Given this list of marker genes H3C14, LDLRAP1, ACAD9, GCDH, YKT6, PPM1M, PTRH1, GSTO1, SERINC3 (NCBI Gene Id 10955), TBC1D24, HGSNAT, ADRB2, PMPCA, SCNN1A, SP6, MCEE, ALKBH4 (alkB homolog 4, lysine demethylase), AK1, LARP1B (La ribonucleoprotein 1B), YPEL5, UNC119B, LHX2, TRIM11, ZNF426, MYD88, TECPR1, CD68, GTF2B, CMPK2, WSB1, ZNF764, DNAJA1, TNFRSF18 (NCBI Gene Id 8784), SKIC8, ATP6V0D1, NANOS1, SLC10A6, PDRG1, GPR146, USP17L24, SLC25A33, NT5DC3, GCH1, PLS3, SLC39A7, PDLIM5, SHMT2, PRKRIP1, EFNB1, MSRB1, TK2, IFNGR2, FTSJ3, BECN1, ENDOD1, OLA1, ROM1, SIVA1, NAT8, TSPAN7, ACAA1, GAL3ST1, GTSE1, TUBB4B, HOXA5, ADAMTS15, EOGT (NCBI Gene Id 79580), CORO1A, PPP5C, ACSL1, TUT7, AREG, ZPR1 (NCBI Gene Id 95155), RIC8A, IMPA1, CRLF1, RAP2A, PURG, GPLD1, GORASP1, KLF17, PNP, CAMP, ASAH2, SLC35D1, SLC45A3, PPP1R37, WDR46, IFITM10, SF3A1, DCXR, TRIM17 (NCBI Gene Id 51127), CABYR, TBC1D1, MLF2, SH3BGRL3, UBA7, QSOX1, KCTD11, TMEM140, CPOX, CELF4, OMP, ICAM5, NMNAT1, RRP9 (NCBI Gene Id 9136), COL4A4, TUFT1, EEIG1, ENTPD7, ATG3, NAPA, BCAP31, NATD1, BMP1, PSMF1, RNF225 (ring finger protein 225), NACC1, PSRC1, RABGEF1, NR4A1, SHISA5, H2BC13, CES2, HYAL1, LIG3, AGTPBP1, CUL4A, P2RY6, CCS, SESN2, UBE2V2, NUDT22, SEPTIN3 (septin 3), CHCHD10, POLR3D, UBN1, SCN1B, BAG1, POLR2A, RUSC1 (RUN and SH3 domain containing 1), RNPC3, MOAP1, ATG9B, DRG2, MARVELD1, NOP9, KCNK2, THBS1, OGFRL1, CDR2, STK17B, HYAL2, MR1, C8orf76, BRIX1, FOLR1, PTGER1, ZNF281, GFOD2, CBARP, CAMK2B, SELENOS, EED, MPP4, NPTX1 (NCBI Gene Id 4884), CSTB, CEP104, FAM32A, INHBB, TPRA1, IFI30, MAP2K3, ABTB1, HERC1, ZNF484, CD14, POLRMT, AHNAK, CCNL2 (NCBI Gene Id 9613), SH2D3C, PPIF, CIRBP, TTC16, LRWD1, OASL, RALGPS1, LTBP2, POM121, DEPDC7 (DEP domain containing 7), FAM8A1, UPF3B, ISYNA1, HAUS2, TGM2, TMC6, PLEC, OVOL1, FAM43A, NDRG4, SLC19A2, IRGM, HMGA1, KLHL10, CLDND1, SCARB1, GTF2F2, PRSS8, CTSV, TOR2A, C21orf91, ATOSB, TAPBP, LPGAT1, TRIM21, GCNT2, TOR3A (torsin family 3 member A), GPAT4, PTGER4, METTL6, C6orf132, NLRX1, DPP7, CD207, S100A3, RHBG, FZD7, USP20, RAB43 (NCBI Gene Id 339122, RAB43, member RAS oncogene family), TNFRSF21, SPON2, KCTD10, HPN, SPC25, DSTN, RGS16, EGR2, ZNRF2, PGRMC1, HERPUD2, PSAPL1, CNBD2, ECM1, DGAT2, DMPK, GALNT3, MACROD2, PEX6, PGF, SH3GLB2, TRABD, MTARC2 (NCBI Gene Id 96692), DRC3, ABHD4, ST14, VWA7, CROT, PTHLH, SDC1, CKAP2, FAM216A, CDK18, SBK1, RDM1, DPH7, C1S, ATP6V1E1, DOLK, TMEM150A, PDLIM7, FHL2, MIDN, FBXO33, TEX9, PDGFB, FRMD8, BCAR1, SLC12A7, EIF1AY, TMEM158, SIMC1, EPM2AIP1, CALHM2, CHP1 (NCBI Gene Id 11261), INPP5D, ADAM1A, SERPINE2, GTF2IRD2B, TUBA4A, CRKL, HSD17B4, LMBR1L, PDE1B, MID2, DEGS1, SPRYD4, SLC35F6, DEXI, HS6ST1, CCDC166, TTC27, WSB2, IRAK1BP1, EPHA2, COL17A1, TMEM132A, RHPN2, SLC25A44, MGAT2, AQP1, VAX2 (ventral anterior homeobox 2), DPCD, PIWIL2, C1QTNF1, NAT9, RPUSD1, NOPCHAP1, TMBIM1, GIPC2, ZNF622, INCENP, S100A1, PYGO2, ADGRL1, DESI1, SPR, CDR2L, PAQR4 (NCBI Gene Id 124222), GNA15, ALOXE3, HES6, WNT7B, INCA1, RGL1, COPS9, GRINA, IVD, EXOC4, DDIT4L, SLC18A1, DCAF1, RAP1GAP, MXD4, PSMB4, TTC39B, SORD, LMO4, TTC13 (NCBI Gene Id 79573), TOP3A, ENTREP3, AAR2, TSPAN33, EIF4EBP1, SMARCAD1 (SWI/SNF-related, matrix-associated actin-dependent regulator of chromatin, subfamily a, containing DEAD/H box 1), CCDC137, TEAD3, ARL16, SLC37A2, OAS2, MCFD2, ANKRD10, GUSB, UBE2I, SF3B5, CDIPT, GBP6, ARMC7, ATP13A2, CCN4, DFFB, IFI44, OASL2P, ZFAND2A, LRRC14, DNAJC9, MDM2, VEGFA, BAIAP2, RETSAT, MSANTD5, LGALS3BP, GFER, RBM4, CLDN23, LASP1, MYO5A, DENR, NFATC2, EXOSC9, PSMB9, LRFN1 (leucine rich repeat and fibronectin type III domain containing 1), SLC66A2, CYCS (NCBI Gene Id 54205), MTHFR (NCBI Gene Id 4524), ALDH2, AMPD2, PATZ1, PLIN2, APOH, AAMDC, ALDH1L1, SEC61A1, SPA17, AP4S1, CREM (cAMP responsive element modulator), MAN2B1, CEP295NL, BTG3, HMG20B, ADAMTS4 (NCBI Gene Id 9507), DBR1, ALAD, RASA4B, TAMALIN, MX1, UBE2T, PSTPIP1, TM2D2, CLEC4G, YIPF2, ITGA6, SNCG, NINJ2, ACOX2, NT5DC2, MITF, TMEM19, NDUFA11, PLEK2, SLC12A2, AOX1, STARD5, ITM2C, ABCB10, ATP6V0B, FAM83H, CPT2, SIAH1, N4BP2L1, ACAD8, PDE12 (NCBI Gene Id 201626), IER5, RHBDD3, MED28, MAPK9, PITPNC1, COL18A1, STARD10, CHAC1 (NCBI Gene Id 79094), CELSR2, INO80B, C11orf68, MCL1, WRAP53, RIPK4, GNL2, TMEM51, ATOX1, SH3YL1, EIF4E3, CDHR4, KIAA2013, SLC12A9, EMC4, GGTA1, MTFR1L, SLC6A8, SLC25A29, ADAMTS7, STAC2, SNX2, PML, SGCA, ALDH4A1, H1-2, UBE2E1, MYO1H, MAP7D1, DCTN3, ISLR, TRIM41, GPN3, PLAT, PITPNM1, UBALD2, FLCN, ENDOG, DDX39A, RFNG, AKR1B1, USP27X, RNF135, GGA2, DNAJB2, TP53INP2, GSTZ1, PHLDA2, KLHL22, TSPAN13, FZD5, PDXP, CXCL10, KLC2, ACADVL, CLBA1, ESRP2, UGT1A1, GSTA2, H2BC4, EXOC8, LRR1, FAM110A, KCTD12, ATF3, PFKFB2, RIPOR1, FOXJ1, ZMAT3, TPCN1, DHX58, ZNF91, LIF, JAK3, FOSB, SAP30, ADA, TRA2A, GADD45A, S100A13, MASP1, PDCD6IP, MTFR2, TGOLN2, C19orf12, SRC, SFI1, IL15, PKDCC, FYTTD1, HSBP1, CD24, C1QTNF5, TMCC2, UGT1A5, PARP12, HACD2, IKBKE, INO80E, DDX60, MRPS25, LGALS9, CXCR4, OSGIN1, FERRY3, RBM43 (NCBI Gene Id 389054), INPP5B, ST3GAL2, GEM, GATA3, UNC5C, CAPN1, INAVA, IDH1, OTUD5, PPCS, EVI2A, SPSB1, GKAP1 (G kinase anchoring protein 1), FAS, SDHAF1, NIP7, EXTL1, FCGR3A, HBA2, VPS37B, IL24, WFS1, NBEAL2, CX3CL1, OPN1SW, GGCT, ZFYVE21 (NCBI Gene Id 79038), ZNF708, OTUB2, DRAP1, F11R, PLAAT3, EGR1, EFNB3, HLA-DRB1, TANGO2, TBC1D8, COTL1, NCOA4, SCIN, CDC42EP3, RHOD, PADI1, FEZ1, NFKBIE, ELOVL7, FLVCR1, SAC3D1, ZBP1, SLC33A1, ITGA2B (integrin subunit alpha 2b), SERPINB5, NHERF2, PTP4A1 (protein tyrosine phosphatase 4A1), EPHX1, MYCBP, MOB2, KLHL42, REN, RDH10, VPS18, PRKCD, LCMT1, LY6D, NMRK1, PRKD2, UBE2F, NID2, USP2, TAP1, TPP1, ZNF346, APOF, TRAFD1, RNF103 (ring finger protein 103), SLC9A1, TESK1, PHGDH, CSF1, BCL2L11 (BCL2 like 11), TGFB3, RNF19B, LDB3, TRMT5, SCMH1, SLC20A1, ZNRF1, CNTRL, IKBIP, IK, ARHGAP39, POLK, PCTP, TCIRG1, ACAD11, UGT1A8, TEPSIN, ZNF385A, ERO1B, RNF4, SGPL1, ZNF219, NMI, ULK1, APOBEC1, TM2D1, LZTR1, MMD, LRRC51, GPAA1, CRACR2B, TMED5, IMPACT, TACC3, HR, ACADSB, CXCL2, EIF3B, ARRDC1 (NCBI Gene Id 92714), CITED2, EDEM1, RNPEP (arginyl aminopeptidase), CSF3, AK4, OPLAH, MNDA, ANKRD17, RASSF5, NCOA1, EIF2B2, ZNF703, SRXN1, BCL2L2, TRIM32, SSX2IP, NUB1, SLC12A4, KLF5, BTG2, IL6R, MARK4, DNAJB9, NFYB, FAH, ABHD5, PADI2 (peptidyl arginine deiminase 2), HAP1, BTG1, HSD11B2, SRF, ELF3, RB1, RNF14, SGPP1 (sphingosine-1-phosphate phosphatase 1), LITAF, DNAJB1 (NCBI Gene Id 3337), MARCKSL1, OAS3, MAK16, SLC31A1, EFNB2, ATP6V0C (NCBI Gene Id 527), EHD1 (NCBI Gene Id 10938), NABP1, ZBTB8OS, ISG15, DGKA, TBX2, UTRN, AGPAT5, ETFDH, SPEF1, MAPRE1, PDPK1, USP18, ERGIC3, ZNHIT3, ENO2, FUCA1, RRAGC, CBY1, SKP1, PMM1, FBXW9, ROGDI, FETUB, ICMT (NCBI Gene Id 57087), THYN1, IFIT3, RTP4, SGK2, LRRC57, FGF18, TP53INP1, AHCYL2, UPP1, MAFG, CETN2, WIPI2, JADE1, MAPKBP1, CCDC117, PAK1IP1, ZNF503, ANGEL1, ENTR1, GPSM1, LBX2, RAB40C, EOLA1, TKFC, DNAJC18, RXRG, TCF7, C9orf78, PLPBP, PRCP, CENPT, SRP14, CYSRT1, CLDN9, JUP, FAM50A, OGFOD2, RABGAP1, NOP16, KLHL25, CHMP1B, IDNK, ISG20, BLCAP, IGFBP4 (insulin like growth factor binding protein 4), UHMK1, CD274, DRAM1, ATP6V1B2, PPM1B, SLC25A42, ARAP1, TMOD1, TIPARP, UBE2O, RXRB, RBM15 (RNA binding motif protein 15), SLC35A5, IRF6, CIMIP3, IFT27, PKP1, PLXNB2, PFN2, EFNA1, CLTB, FOSL1, ERBB3, GPD1, GNA13, CLCC1, GSS, SPNS1, CTSE, LPIN1, MAFK, DUSP9, ZNF296, SRR, MAVS, SLC39A4, IL18, GLUD1, PLA2R1 (phospholipase A2 receptor 1), RIN2, ARHGAP27, G3BP1, RSAD2, ZNF185, PTPRVP, SGF29, HIGD1A, RGN, UGGT1, ST6GALNAC4, TIMM22, SIRT7 (sirtuin 7), KRT14, MAP1LC3A, PTGR1, DAXX, MLH3, PVALB, FBXW4, DNM2, TLR3, RAD9A, PDK4, CASQ2, PM20D1, PLA2G12A, ITGB4, STAT2, SLC35E4, PHYKPL, CLASRP, RAP2B, SLAIN1, BET1L, PTPRM, NINJ1, FBXL20, MORC4, ALOX12, STIM1, PSTPIP2, DUSP6, FICD, TRIM34, CAPG, PPM1A, HMOX1, TAF13, CRABP2, DOP1B, CBX1, PYHIN1, GLCCI1, PDLIM1, DCBLD1, SLC25A22, STRAP, PHLDA3, TMEM40, MRPL28, PA2G4 (NCBI Gene Id 5036), CRAT, KDM5B, HBEGF, SLC7A7, APAF1, KIFC3, GDE1 (NCBI Gene Id 53591), DOK4, GBP4, MUSTN1, POLE3, HAGH (NCBI Gene Id 3029), PTPN11 (NCBI Gene Id 84990), ZNF593, CAPRIN2, PLK2, HELZ2, ADAM8, SIRT1, OAS1, GGNBP2, PLEKHA4, NAA35, ECE1, UFD1, GLUL, CRELD2, GALM, PEX26, CFAP184, GLRX3, PLEKHG6 (pleckstrin homology and RhoGEF domain containing G6), ARAP2, TREX1, LRRC56, FAM117B, GCC1, ITPKA, IRF7, OSER1, UFSP1 (UFM1 specific peptidase 1), NPC2, IL17D, ESRRA, ARVCF, USP38, CTSB, ZRANB1, CDKN1A, RPS27, PPP6R3, CDK5R1, SMOX, SLC25A25, TRIM5, ZC3H12C, SLC66A3, ZAP70, PTPN1, SIDT2, FGFR4 (fibroblast growth factor receptor 4), CCL2, MAL2, FBXO2, SMIM3, STAU1, LENG1, ZFTRAF1, CARHSP1, SNX16, WIPI1, FDXR, CEP112, LACTB, RPE, CAPN10, SPINT1, PIGF, DCAF4, CCPG1, TWF2, CTR9, LRRC8A, WDR45, RNF128, PDE4DIP, FOS, NUDCD2, PPP1R15A, CCDC86, DGAT1 (diacylglycerol O-acyltransferase 1), TMEM191C, PLA2G6, SP110, ACTR1B, RNF181, ASS1, HRAS, STAT1, SMIM7, CAVIN1, TNPO2, AEN, CDC25A, IFIT1B, FA2H, TMEM38A, DDR1, PLK3, ALAS1 (5'-aminolevulinate synthase 1), ELAPOR1, RCAN1, CRB3, PERP, LYNX1, RNASEH2C, ALDH1A1, HAS2, PLCB3, RGCC, AHR, CORO2A, APOL1, GTPBP1, RCN2, H2AC25, SLX9, GDF15, IPPK, PRKRA, CITED4, PKP3, H3C13, SLC30A1, ADAM15, TCIM, ARPP21, MXD3, PPP2R5D, PLEKHA3, CLP1, RAB11FIP5, LANCL1, VASN, HSPA1B, STX3, PDCD10, GTF2A1, GPHA2, MAFB, SAP30BP, HEXIM1, TMEM41A, HEXB, TFCP2L1, CYP2F1 (cytochrome P450 family 2 subfamily F member 1), TOB2, ATP6V1D, CXXC5, ANGPT4, TLR2, IFIH1, PIAS3, IDUA, GSN, SOX4, PPA1, E2F1, TMEM184B, CCNG1, ZNF394, CPEB4, TRPT1 (tRNA phosphotransferase 1), JPT1, IGSF8, SMPD4, MPHOSPH8, KIF22, FKBP9, PADI3, HHATL, RFLNB, ERCC5, SUSD6, TTLL1, DDIT3, DAPK1, GPANK1, ITPA, ATP6V1C1, ZBTB8A, MDH1, SYVN1, ATG101, SURF4, DAB2, GBP2, MFRP, URM1, ACOT6, JUNB, C22orf23, NAA80, MMP15, CRIP2 (cysteine rich protein 2), NXN, PNPLA2, XAB2, GNS, ACOX3, IL4R, SPHK2, RBL2, PROCR, UGT1A6, RABEPK, SRMS, COL11A2, SEPHS2, MSH6, MAPRE3, SAP18, XRCC1, PCYOX1, C19orf47, RIDA, SLC27A1, TRIM7, TRAF4, ZFP36, RBM38, KIF17 (NCBI Gene Id 57576), BMAL1, ZMIZ2, PSME3IP1 (proteasome activator subunit 3 interacting protein 1), ATP6V0E2, PARG, DGKQ, PITPNM2, TNNI1, RECQL4, EI24 (EI24 autophagy associated transmembrane protein), JOSD2, EHD4, DBT (NCBI Gene Id 1629), FOXQ1 (forkhead box Q1), PSMC3IP, EAF2, SHISA2, RDH5, COMP, CENPE, ANGPTL2, PNPT1, SP100, IFI35, NOCT, C4B, PDGFA (NCBI Gene Id 5154), RTRAF, LMAN2, EMP3, SH3BGRL2, CLSTN3 (calsyntenin 3), BST2 (NCBI Gene Id 684), MAPKAPK2, MFGE8, KRT5, here is a description of the gene set: Human Gene Set: GRAESSMANN_APOPTOSIS_BY_DOXORUBICIN_UP Impairment of the complex regulatory network of cell death and survival is frequently the reason for therapy resistance of breast cancer cells and a major cause of tumor progression. We established two independent cell lines from a fast growing mouse breast tumor (WAP-SVT/t transgenic animal). Cells from one line (ME-A cells) are sensitive to apoptotic stimuli such as growth factor depletion or treatment with antitumor agents (e.g. doxorubicin). Cells from the second line (ME-C cells), which carry a missense mutation at the p53 codon 242, are very insensitive to apoptotic stimuli. Co-cultivation experiments revealed that the ME-C cells mediate cell death resistance to the ME-A cells. Microarray and Western blot analysis showed that osteopontin (OPN) is selectively overexpressed by the ME-C cells. This glycoprotein is the most abundant protein secreted by the ME-C cells and we obtained strong indications that OPN is the main antiapoptotic factor. However, the OPN containing ME-C cell medium does not alter the expression level of pro- or antiapoptotic genes or known inhibitors of apoptosis (IAPs). Its signaling involves mitogen-activated protein kinase (MAPK)/extracellular signal-regulated kinase (ERK) kinase (MEK)1/2 as the kinase inhibitor PD98059 restores apoptosis but not the Akt inhibitor. In the ME-A cells, mitochondrial cytochrome c release occurs with and without external apoptotic stimuli. OPN containing ME-C cell medium does not prevent the mitochondrial cytochrome c release and caspase-9 processing. In serum starved ME-A cells, the OPN containing ME-C cell medium prevents caspase-3 activation. However, in doxorubicin-treated cells, although apoptosis is blocked, it does not inhibit caspase-3. This indicates that the ME-A cells distinguish between the initial apoptotic stimuli and that the cells possess a further uncharacterized control element acting downstream from caspase-3. Genes up-regulated in ME-A cells (breast cancer) undergoing apoptosis in response to doxorubicin. studied in species Mus musculus from publication Graessmann M, Berg B, Fuchs B, Klein A, Graessmann A (PMID 17160024)